Given this list of marker genes Pawr, Nr1h2, Ghrl, Crh, Prap1, Oxt, Negr1, Slc22a21 (NCBI Gene Id 56517), Ppp3ca, Aqp1, Ghsr, Enpp7, Slc22a5 (NCBI Gene Id 20520), Acat2, Npr3, Sct, Lpcat3, Tac4, Cyp8b1, here is a description of the gene set: Any process that increases the frequency, rate or extent of a digestive system process, a physical, chemical, or biochemical process carried out by living organisms to break down ingested nutrients into components that may be easily absorbed and directed into metabolism. studied in species Mus musculus Mouse Gene Set: GOBP_POSITIVE_REGULATION_OF_DIGESTIVE_SYSTEM_PROCESS